Given this list of marker genes RESP18, NDUFS2, SSBP3, CPE, NUDT22, ACER2, CCDC107, DDAH1, MRI1, NDUFB11, ELOC, C10orf88, ARHGDIB, SF3A3, PCSK1, EEF1D, EIF3H, FCF1 (FCF1 rRNA-processing protein), FMO5, CDO1, POLR2I, MAPKAPK5, DPY30, EIF1, PDE6G (phosphodiesterase 6G), NUBP1, VTA1, HSD17B8, HINT1, EAPP, ZFAND1, MAGED2, MESD, LIN37 (NCBI Gene Id 55957), SLC7A6OS, RSRC2, AP4S1, LRRC45, POLR1E, R3HCC1, NAP1L4, SNAPC5 (NCBI Gene Id 10302), BLOC1S4, STAMBPL1, MED4, ICAM2, MRPL58, PDCD4, UQCRFS1, CRTAM, NANP, TRMT10C, CD96, MIR151A, RPS4X, TNFRSF18, TGIF1, NT5C, MUL1, MRRF, ZMYND11, RPL7A, PRXL2C, GPATCH11, GLRX5, TSPAN6, NHEJ1, PLCB4, NLE1, CLK2, PRAF2, PPP2R3A, RDH14, CLYBL, SLC6A2, WDR83, SEC62, EPHX1, GALNT4, SCNM1, MAF1 (NCBI Gene Id 84232), SPINT2, GTF2B, MTFMT, ANKRD34C, APPL2, YPEL3, GPR183, DNAJC7, RPL23A, PMF1, IZUMO4, PDCD6, CHST4, RARG, PNN, ARHGDIG, DDC, GBE1, PRKRIP1, ARHGDIA, TMEM9B, AEBP2, HDAC3, BRME1 (break repair meiotic recombinase recruitment factor 1), SNRPC (NCBI Gene Id 6631), SPAG7, TVP23B, BLOC1S5, IGBP1, CTNNBL1, FAM118A, ISOC1, REEP4, RPL29, NT5C3B, DAPL1, SKIC8, PFN2, DNAJC15, COX7A2L, CDK11B, C2CD6, CCNQP1, PUS3, CNEP1R1, AMPD1, RBM22, HNRNPC, EYA2, ANKRA2, SPHK2, LAT, MIIP, CACNB1, MRPL44, TMEM9, LSG1, SYF2, TOR1A, NTRK3, CMAS, RBMX2, MPST, DYNLRB1, SCARNA17, JPT1, TMEM108, FSIP1, TRUB1, C11orf68, RPS26, C22orf39, ANAPC15, TAF8, TMEM50A, EIF3D, SAP18, ZEB1, SLC25A3, PRKAG1, LSM7, RRP36 (NCBI Gene Id 95840), ZXDC, GNPTG, NFU1, RHBDD3, MTFR1L, DNTTIP1, WRAP73, NMT1, here is a description of the gene set: from publication Ramirez K, Chandler KJ, Spaulding C, Zandi S, Sigvardsson M, Graves BJ, Kee BL (PMID 22608498) studied in species Homo sapiens Human Gene Set: GSE37301_HEMATOPOIETIC_STEM_CELL_VS_PRO_BCELL_DN Genes down-regulated in hematopoietic stem cells versus pro-B cells. Expression profiling of Rag2-deficient Ets1++ and Rag2-deficient Ets1-- mature NK cells and WT bone marrow progenitors, WT T cells, and WT Pro B cells